The following is a description of a gene set: Genes up-regulated in bone marrow-derived macrophages treated with IL4 and rosiglitazone: wildtype versus PPARG knockout. Human Gene Set: GSE25123_WT_VS_PPARG_KO_MACROPHAGE_IL4_AND_ROSIGLITAZONE_STIM_UP Conditional macrophage-specific PPARg knockout mice were generated on C57Bl/6 background by breeding PPARg fl/- (one allele is floxed, the other is null) and lysozyme Cre transgenic mice. PPARg and IL-4 signaling was analyzed on bone marrow-derived macrophages. Bone marrow of 3 mice per group was isolated and differentiated to macrophages with M-CSF (20 ng/ml). 20 ng/ml IL-4 was used to induce alternative macrophage activation and 1 uM Rosiglitazone (RSG) was used to activate PPARg. From each mouse 4 samples were generated: 1. M-CSF, 2. M-CSF+RSG, 3. IL-4 and 4. IL-4+RSG. All compounds were added throughout the whole differentiation process, and fresh media was added every other day. Control cells were treated with vehicle (DMSO:ethanol). After 10 days, RNA was isolated and gene expression profiles were analyzed using Mouse Genome 430 2.0 microarrays from Affymetrix. from publication Szanto A, Balint BL, Nagy ZS, Barta E, Dezso B, Pap A, Szeles L, Poliska S, Oros M, Evans RM, Barak Y, Schwabe J, Nagy L (PMID 21093321) studied in species Homo sapiens, and this is the list of marker genes: CLEC3B, RAB43, PTPA, MCPH1-DT, CCDC138 (coiled-coil domain containing 138), BFSP1, SERPINH1 (NCBI Gene Id 89588), MANEAL, FOXB1, GNL2, SNHG11, SERPINE2, GRAPL, NRGN, C16orf86, TOMM40, IL18BP, DHRS12, NOBOX, SOX8, ASL, TBX20 (NCBI Gene Id 57057), SNX24, AGPAT2, AOAH, RIPOR2, CIAPIN1, CLIC4, SMYD3, CHMP3, C21orf91, GFOD1, CSNK2B, POGLUT2, GPAT2, TNFSF13, PHF13, C12orf43, TMEM120A, B4GALT7, SEPTIN1, WASIR2, DAZAP1, MCFD2 (NCBI Gene Id 90411), NBL1, ATG4D, CADM1, PRELID3B, IKBKG, ZNF815P, CCPG1, CDH9, NT5C, WDR18, RASSF8-AS1, SEPTIN10, LINC00667, CUL7, PRSS53, THUMPD3, C3orf80, CNNM4, FBXW8, OASL, LUC7L2, CENPV, ATG101, CCDC9, DUSP7, NOXRED1, HCG11, EXPH5, KIF1C, ADAMTS19, PMM1, RAB23, ERCC8, CCDC13-AS2, GUK1, CHID1 (NCBI Gene Id 66005), PGD, CARD10, GAREM2, CNN2, BCKDHB, STUB1, CARS1, CFAP299, ADA, TAGLN2, C19orf25, CELSR2, DCTN5, ASPHD2 (NCBI Gene Id 57168), CENPB, RPIA, BCKDHA, PYGO1, LHPP, MTBP, ZNF17, LINC01405, AVEN, CNP, PNLIPRP2, UBE2J2 (NCBI Gene Id 55482), UBE2J1, ENSG00000286546, RMND5B, FOXO4, SGTA, CAMK1, ZNF813, PPARD, RYR3, UBE2I, ASB9, ACOXL, NINJ2-AS1, ADRB2, TTC7B, TRAC, CHD2, TUFT1, NEURL2, KRT8, YJEFN3 (NCBI Gene Id 374887), NCKIPSD, ST3GAL4, TUBBP5, SPRING1, TTYH2, C22orf39 (chromosome 22 open reading frame 39), IGHM, DNAJB4, TMEM255B, EIF5A2, ILF2, CTAGE9, PNMA8A, ELOVL1, SCN9A, GTF3A, CIMAP1B, IMPA2, HS6ST3, CHI3L1, SIX6, BIRC5, CPPED1, ZNF436-AS1, HEXA, GIPC1, MMAA, KBTBD11 (kelch repeat and BTB domain containing 11), SCRN2, ATP2C2, CRELD2, EEF2K, TMBIM6, B4GALNT4, CHAF1B, SMARCB1, TMEM39B (NCBI Gene Id 55116), SLC26A4-AS1 (NCBI Gene Id 286002), ACTL10, KLF1, HMCES, PTPRCAP, ACOT7, OGFOD3, ELMOD3, BRF2, PLEKHB1, FBXO41, OSTF1, IVD, CENPQ (centromere protein Q), NKX2-8, MN1, LINC03104, ROBO1, MRPL38, SLC27A1, C20orf141, ZNF569, DGCR5, MYO1C, FLT1, CYP4F8, THAP5, HS3ST3B1, OTOS, HACL1, B3GALT2, ZDHHC20, SLC25A10